Given this list of marker genes RAC2, NF1, STAT5A, KITLG, KIT, LYN, ENPP3, STAT6, here is a description of the gene set: studied in species Homo sapiens The expansion of a mast cell population by cell division. Human Gene Set: GOBP_MAST_CELL_PROLIFERATION